Given this list of marker genes CD74, DMD, SCN5A, CAV1, SNTA1, CALM3, NOS1AP, CAV3, ATP2B4, SLC6A4 (solute carrier family 6 member 4), ACTB, here is a description of the gene set: species: Homo sapiens Binding to nitric-oxide synthase. Human Gene Set: GOMF_NITRIC_OXIDE_SYNTHASE_BINDING